The following is a description of a gene set: Genes having at least one occurrence of the motif WTGCGTGGGCGK in the regions spanning 4 kb centered on their transcription starting sites. This matches the EGR1 transcription factor binding site V$EGR1_01 (v7.4 TRANSFAC). Human Gene Set: EGR1_01 studied in species Homo sapiens, and this is the list of marker genes: VGF, YPEL4, NUFIP2, C9orf72, KLF3-AS1, RAPGEFL1, HMGA1, BRD2, CLPTM1, PCIF1, RPS6KA3, PCDH17, MAN2A2, MSI1, VAMP2, LRATD2, THOC6, HR, MNT, DNAJB5, KLF16, ERRFI1, HCN4, ISG20L2, RASSF7, IWS1, FZD1, HHEX, KCNS2, USP1, REXO2, FAF1, AIFM1, NRGN, SOX12, CEP95, TAF11, SPTB, NRK, PITPNA, EGR1, KAT2A, CGGBP1, CACNA1E, CBLN1, HAS1, FRA10AC1, ATOSB, KLF3, ATP1B2, CDK17, FUS, PRRT2 (NCBI Gene Id 81865), PABIR2, ANKH, PLEKHH3 (pleckstrin homology, MyTH4 and FERM domain containing H3), TAOK2, ANKS1A, PTCH1, RSPRY1, NOP53, HRK, ZFPM1, SLC25A23, NT5C3B, AMMECR1L, MRC2, SELENOF, KCNB2, STARD13, LMNTD2, TPBG, PAFAH1B1, UCHL3 (ubiquitin C-terminal hydrolase L3), ZNF827, NAB2, KCNC1, SLC25A38, HMGN2 (high mobility group nucleosomal binding domain 2), ICAM5, PBX1, PJA1, AP3S1, TBX3, TPGS2, TFE3, GPHN, ELL, CTCF, TCTA, SHF, TTC9C, CDKN2C, IGF2BP1, CMAS, SMARCA5, PARP6, ARL1, SF1, EPHB1, CEP70, EGLN2, SLC9A7, SDCCAG8, EHBP1, PTPN7, KREMEN2 (kringle containing transmembrane protein 2), TPM4, ZNF414, DDX6, AKIRIN2, TUG1, AKAP12, XPR1, GNB2, MAP3K4, FEV, VTN, CARNMT1, MSL2, ITGB8 (integrin subunit beta 8), RALGPS2, RBBP6, PPARGC1B, APLP2, PRKACA, HOXA2, WDR44, CNOT6L, KCNQ5, CDH2, RHOA, KCND2, RAB26, EGR3, KDM2A, SH3BP1, GRIN1, ERF, KCNN2, NIPBL, ZMYM2, CNNM4 (NCBI Gene Id 619531), KCNB1, PRKAG1, DVL2, TNFRSF12A, MEF2C, RAB39A, ACE, NEUROD2, SH3KBP1, ATE1, ZNF232, ZBTB5, KCNAB3, HOXA7 (homeobox A7), RNF24, TFAP2C, SCN8A, NPAS4, PCSK2, IRF2BPL, METTL25B, PACSIN2, UBTF, SSTR3, NDUFA4L2, PSME3IP1, PLOD3, SLC22A17, ARRDC1-AS1, FOXP2, BAHD1, NFYC, HYAL2, MYB, TRA2B, HMGN1, SIK2, OTX1, WDR48, CLTC, EIF5A, GSX1, GRB2, C12orf75, SYVN1, XK, PDGFB, APP, SP1, SPRED1, GLRA3, DYNC1LI1, PTMS, VEGFA, NLK, ING2, HSPB9, TLE3, HOXB8, SEC14L1, GIT1, MORF4L2, KLHL10, CREB3L1, CSMD3, SREBF2, HCFC1R1, PABIR1, RHOB, CRTC2, BRWD3, RELB, MATR3, MGLL, CBARP, CORO1C, PCOLCE, ORC4, MACO1, CAMK2A, TLE4, KCNH5, SOCS5, PRPF3, ETV4, DLL4, HNRNPDL, TBC1D10A, CAND1, RPUSD4, ZNHIT1, SRCIN1, SH3GL3, CLSTN1, ALKBH7, DDX5, SMYD5, AP1G1, EFEMP2, KRCC1, DYNLL1, ARF3, QRICH1, GPR132, ADSS2, NUMBL, CACNA1A, RFX4, UBXN10, YWHAE (NCBI Gene Id 7531), RUNX1, UBASH3B, RASGEF1A, SERTAD1, LEF1, TRIB1, SARM1, IMPDH1, CNN2, DLX4, L1CAM, LRFN5, KAT7 (lysine acetyltransferase 7), LYPLA2, PORCN, ATG12, HOXA5